Given this list of marker genes P2RX1, GALR3, HTR6, HCRT, GLRB, UNC119, CHRM1, CNP, SYT1, KCNMB1, VIPR1, GRM4, KCNQ3, MAPK8IP2, GABRB1, NTSR1, GRIK2, OPRK1, CHRNA7, NCAM1, GABRB3, DRD4, SLC1A3, NOS1, SLC6A2, GRIK1, CBLN1, MAPK1, CHRNB1, ABAT, GRM2, GABRA5, SYN1, HTR3A, GABRE, GRM3, SLC1A6, SNAP25, GLRA2, NOVA1, GAD2, ANK3, DNM1, DRD3, NQO1, CHRNE, GAD1, CHRND, CPNE6, GABRA1, NPTX1, CHRM3, CORT, PNOC, SCN1B, RAPSN, SCN2B, SYN2, SLC6A7, CHRNB2, SYT5, GRIN2A, SLC1A1, CHRNB4, GABRG2, DRD2, HTR7, SST, ASIC2, KCNK3, SULT1A3, CHRNB3, GRIA2, APBA1, DLG4, KCNN1, HTR2A, SLC6A8, DOC2A, KIF5A, AMPH, GRIN1, here is a description of the gene set: Human Gene Set: MODULE_274 Vesicular transport / synapse genes. species: Homo sapiens